Given this list of marker genes MRPL40, ATP5PD (NCBI Gene Id 519), STAR, MIEF1, ABCB8, DARS2, MFN2, UQCRFS1, PTRH2, SIRT5, PLN, MRPL21, COX6B1, NDUFB3, TOMM20L, CMC4, PLA2G4C, GK2, MSTO1, MRPL3 (mitochondrial ribosomal protein L3), MRPS27, DNAJC15, MRPL13, SIRT4, UCP2, DUSP18, MRPS28, DNAJC11, ANTKMT, CLPX, TRIM14, OXA1L, MYO19, VPS13C, NBR1, SFXN5, PRELID2, ALPL, PNPT1, NIPSNAP2, THG1L, FOXRED1, HSPA9, BCL2L13, COX7A1, TRMT10B, SLC25A38, RTN4IP1, TMEM126B, ACADM, SPART, NDUFAF4, COQ4, IMMP1L, SOX10, WASF1, VDAC1, CYP27A1, IFI6, SLC9B2 (solute carrier family 9 member B2), UQCRC2, CIAPIN1, ERAL1, GDAP1 (NCBI Gene Id 54332), SELENON, MRPS16, GPAT2, COQ9, MRPL1, BCL2L2, TAMM41, NDUFV3, BCL2, CHCHD1, CEBPZOS, SLC22A4, SLC25A28, MICOS10, COA1, TIMMDC1, NDUFAF1, ACOT9, TOMM5, ETFDH, ASS1, MAPK8IP1, ABCB10, FGR (FGR proto-oncogene, Src family tyrosine kinase), UFL1, TAFAZZIN, TMEM177, UQCC6 (NCBI Gene Id 732143), MRPS25, MRPL12, ABCG2, SLC25A46, ENSG00000293600, PISD, NDUFB2, TRAP1, NEU4, DCAKD, PRNP, MRPL4, GABBR1, STARD13 (StAR related lipid transfer domain containing 13), NDUFS6, PGR, CYB5A, QTRT2, PHB1, PSEN1, ATPAF2, MRPS22, MRPL35, SLC30A2, MRPL54, MIGA2, NDUFB4, SLC22A14, MT-ND1, ADAP2, SLC25A16, CPT1B, MICOS13 (NCBI Gene Id 125988), ROMO1, SLC25A22, C11orf65, TMEM14B, PANK2, GHITM, TMEM14A, BNIP3L, MISFA, CYC1, MRPL41, MRPL19, PTPN1, MRPS34, UQCRH, SOD1, COX8C, KCNK9, NDUFB10, MARCHF5, FPGS, HMOX1, ATP5MJ, COX11, PDSS2, FAM210B, COX7B2, CPS1, BNIP1, SPHK2, COA5, ACADL, MGST3, MRPL48, SRC, SLC25A21, MPV17, RAC2, QTRT1, PMPCA (peptidase, mitochondrial processing subunit alpha), PEMT, SLC39A9, RAB5IF, MRPL33, NDUFB7, MTG2, MRPS7, FLVCR1, DMAC1, GPER1, CYB5B, RARS2, SLC25A12, BECN1, ATPSCKMT, CIBAR1, NDUFC1, ATXN3, GRK2, FOXO3, AGK, SMIM30, SPG7, ACAD11 (NCBI Gene Id 84129), CLU, CYCS (cytochrome c, somatic), DMAC2L, KIF28P, MRPL37, SLC25A18, NDUFC2-KCTD14, SLC25A39, CFL1, SDHAF3, MTARC1, PET100, COX4I2, PDSS1, COQ5, COX18, TIMM9, VPS13A, ATPAF1, RAB7A, ATAD1 (ATPase family AAA domain containing 1), RHOT1 (NCBI Gene Id 55288), IKBKE, NDUFB9, ATP5PF, NDUFAF5, ATP5MF (ATP synthase membrane subunit f), ATP5PO, SLC25A20, NDUFAF2, HSPD1, BCL2L1, SLC25A24, CHCHD5, BDH1, ATP5F1D (NCBI Gene Id 513), VDAC3, MTFP1, PLEC, CDS2, GCAT, CYP27C1, MAP1LC3B, NDUFS2, UQCC2, PHB2, REEP1, VDAC2, CYP2E1, NME3, FLVCR2, NDUFB6, TMEM242, SLC25A51, ATP5F1B, CKMT1B, COX7A2L, MRPS11, RNF144B, MPV17L2, TMEM14C, MTNAP1, MT-ATP6, PRELID3B, MFN1, CALM3, MRPL2, SLC27A3, MIX23, TIMM29, MRPL32, COX8A, TRAF3IP3, MCUB, NDUFB5, TIMM17B, ABHD6, NNT, SLC25A6, RMDN3, UBB, NDUFA7, UBIAD1, PNPLA8, ABCD1, MT-ATP8, SLC25A33, TOMM40, SFXN4, BBC3, BOK, APOOL, AIFM3, BRI3BP, RSAD2 (NCBI Gene Id 91543), FATE1, APP, GRAMD4, CRAT, FBXL4, CRLS1, SLC25A29, ATP5F1E, CNR1, HSD3B2, DUSP21, SLC25A10, SLC22A3, TTC19, NDUFS1, KGD4, NDUFV2, THOP1, UQCRC1, UQCRB, CYP11B2, AURKAIP1, ACACB, SCO1, SLC25A27, UCP1, PARK7, SMDT1, UQCC1 (NCBI Gene Id 55245), MRPL9, SPNS1, GRPEL2, FKBP8, MT-CO1, MRPS18B, LYRM7, PLA2G4B, CISD1, MRPL20, ATF2, TSPO2, NDUFAB1, MRPL52, TOMM20, MRPL11, TMX2, CYP2U1, CEP89, VAMP1, C19orf12, MYOC, NDUFA11 (NADH:ubiquinone oxidoreductase subunit A11), BCL2L11, SLC25A4, PGAM5, MRPS2, MICU1, MRPL51, UQCR11, ACSL6, MPC2, AFG3L2, MTERF3, MTOR, ATAD3A, MRPS9, ARMC1, TIMM23, MRPS26, COX6B2, UBA52, SLC30A9, NDUFS8 (NADH:ubiquinone oxidoreductase core subunit S8), ARL2BP, PLA2G4A, ACSL1, PLSCR3, NDUFV1, ACSL4, SMIM26, SLC25A31 (NCBI Gene Id 83447), YME1L1, BID, PRODH, NRGN, MRPS5, PLAAT3, CYP24A1, OGT, ZNFX1, LYN, PI4KB, PPP1CC, MRPS30, ARMCX3, MAOB, CPOX, MFF, MTHFD2L, ARL2, MRPL46, HK2, ATP5F1A, SLC25A32, COX7C, UQCRQ, SAMM50, HK1, SFXN1, COQ3, COQ7, TRABD, LDHD, SLC25A19, COA7, COX15, RNF185 (NCBI Gene Id 91445), TIMM10, MRPL17, SH3GLB1, EPHA4, RHBDD1, MRPL28, HSD17B8, MAPKAP1, GOLPH3, MTX3, SLC29A3, NDUFAF3, RPS3, UCP3, CCDC90B, RAF1, COX6A1, SLC25A26, ACSL3 (NCBI Gene Id 55484), MRPS10, SFXN2, SLC8A3, AKT1, NDUFB11, GADD45GIP1, HSD3B1, SLC25A5, THEM4, TRAK1, BCL2L10, PLEKHN1, MRPL15, PLA2G2A, MPC1, TIMM50, EXOG, SLC25A40, ARMCX6, MRPS12, SPATA19 (NCBI Gene Id 219938), MRPL10, MRS2, ATP5MC2, SLC25A37, DEGS1, SHMT2, CISD2, CHCHD4, IMMT, ENDOG, ATG9A, RAB32, DELE1, MAOA, MRPL45, DHFR2, MAIP1, MRPL50, ARMC10, TRIAP1, SMCP, STAT3, HADHA, SLC25A42, LPIN1, FKBP10, TOMM7, TMEM11, GK, PTPMT1, VRK2, NDUFS3, MOAP1, PAM16, MTCO2P12, BLTP2, SLC25A2, FDXR, SLC25A52, SCO2, VAT1, SLC25A1, TMEM70, ANGEL1, PRKCA, GFER, MTFR1L, OMA1, ATAD3B, CHDH, ATP5ME, COA3, TMX1, MRPL36, SLC25A14, EXD2, ATP5F1C, ALAS2, ALDH18A1, REXO2, NDUFS4, HKDC1, ZDHHC8, CKMT1A, COX17, PPTC7, SLC25A15, TMCO1, MT-ND2, NDUFA4, SLC8B1, COQ6, BPHL, BIK, ATP5MGL, COX20, TIMM8A, MGST1, MRPL39, PTCD3, MRPS24, RPS27A, MRPL47, DNAJC30, NDUFA12, GPD2, ACADVL, LETMD1, PLD6, YWHAE, SLC25A3, NDUFAF6, MRPL22, SUOX, LGALS3, L2HGDH, ARMC12, ACAD9, RDH13, ATCAY, COX16 (NCBI Gene Id 51241), BMF, ACSL5, PGS1, IFI27L1, SDHB, KMO, SURF1, TIMM21, COQ10A, CKMT2, COQ10B, STING1, MICU2, STOML2, IFI27, ATP5MC3, MRPL44, IFI27L2, ATP5MG, CHCHD6, BNIP3, OGDH, MTCH2, SLC25A13, GPAM, SLC25A44, PRELID1, CHCHD7, PARL, SLC25A47, DNAJC19, BCL2A1, CHCHD3, HTRA2, ULK1, MRPS35, ATP5PB, SLC25A36, COX19, AQP8, TOMM40L, MRPS31, SEPTIN4 (NCBI Gene Id 5414), AIFM2, MRPL27, GRPEL1, MCUR1 (mitochondrial calcium uniporter regulator 1), TMEM186, SLC25A30 (solute carrier family 25 member 30), AGPAT4, MRPL30, DAP3, TOMM6, AMBP, SARM1, MTG1, COQ2, RHOT2, SLC44A2, TMEM126A, MT-ND4, HADHB (NCBI Gene Id 3032), MTX2, NDUFS7, NOA1, MT-ND5, MCL1 (NCBI Gene Id 4170), PMAIP1, UBC, TMEM14EP, SLC25A41, MRPL58, MPC1L, COQ8B, NDUFA1, NDUFA10, MCU, NDUFA3, SQOR, CANX, COX5B, SMIM20, CARD19, RHOD, HCCS, PINK1, COX4I1, MT-ND3, MRPL57, MLXIP, APOO, HIGD1A, GUF1, MT-CO2, SNCA, STMP1, SLC11A2, MT-ND6, NDUFB1, MRPL53, FAM162A, COX7B (NCBI Gene Id 1349), MRPS17, UQCR10, BAD (NCBI Gene Id 572), TIMM8B, UQCC4, SLC25A43 (NCBI Gene Id 203427), COA6, CYP11A1, NGRN, FUNDC2, PRODH2, NDUFA9, ADCK1, ELK1, TOMM22, FZD9 (NCBI Gene Id 8326), CPT2 (NCBI Gene Id 1376), MT-CO3, COQ8A, MRPS21, OPA1 (NCBI Gene Id 4976), COX7A2, HSP90B2P, MRPL55, FECH, CHCHD10, AK2, UQCC5, MT-CYB, RPS6KB1, PRKN, TIMM17A, AIFM1, SLC25A45, TSPO, SORD, LRRK2, BCS1L, NME4, TIMM44, ALAS1 (5'-aminolevulinate synthase 1, NCBI Gene Id 211), CYP11B1, TIGAR, ATP5MK, BLTP1, TIMM10B, SLC41A3, EFHD1, CYP27B1, MRPL34, MIEF2, PDE2A, MRPL49, GSDMD, FIS1, MRPS15, PPOX, COX6C, OTC, SNN, MTLN, ARMCX1, MRPS23, NDUFS5, CLPB, NAT8L, SYNJ2BP, TMEM135, TIMM13, UQCC3, DNM1L, ECSIT, SLMAP, DIABLO, NLRX1, SLC25A53, LETM1, HIGD2A, MTCH1, TDH, MRPS33 (mitochondrial ribosomal protein S33), MRPL18, AMBRA1, MRPL38, DHODH, RNASET2, COX14, CABS1, ARMCX2, SDHC, PPIF, PPP1R15A, RCC1L, CDC25C (NCBI Gene Id 995), NDUFA8, CHCHD2, BAX (NCBI Gene Id 581), UQCRHL, AFG1L, MUL1, SLC25A35, KRAS, CIDEA, DMPK, TMEM160, MT3, PIGBOS1, MRPS14, TUFM, COX7A2P2, TOMM34, CCDC51 (NCBI Gene Id 79714), SFXN3, NDUFA6, COA8, LDHB, COASY, PRELID3A, LETM2, NDUFA13, SLC25A11, AKAP1, NDUFC2, TWNK, PPP2R2B, MTX1, ABCB7, SPATA18, KCNK16, BAK1, SDHA, PGRMC1, MRPL24, TOMM70, GATM, NDUFB8, RAB11FIP5, MRPL16 (NCBI Gene Id 64997, mitochondrial ribosomal protein L16), TIMM23B, SLC25A23, MRPL43, HINT2, USP30, SLC25A34, MRPS18A, MTARC2, NDUFA2, TMEM223, SLC25A48, HAX1, IMMP2L, RNF5, MGARP, COX6A2, CYP1A1, TMEM65, NLN, IRGM, ATP5F1EP2, MRPL14, TIMM22, TYMS, DAO, ATP5MC1, COA4, SLC25A25, COX10, SLC44A1, MAVS, SERAC1, TMEM14DP, MT-ND4L, CPT1A, COX5A, FUNDC1, MRPS6, MIGA1, NME6, MRPS18C, SPIRE1, NRP1, BLOC1S1, CASP8, CYB5R3, ABCB6, MICU3, NDUFA5, SDHD, AGPAT5, MRPL42, MRPL23, STARD7, here is a description of the gene set: studied in species Homo sapiens The double lipid bilayer enclosing the mitochondrion and separating its contents from the cell cytoplasm; includes the intermembrane space. Human Gene Set: GOCC_MITOCHONDRIAL_ENVELOPE